Given this list of marker genes Pln (phospholamban), Hrc, Atp2a1, Mrln, Strit1, here is a description of the gene set: Mouse Gene Set: GOBP_REGULATION_OF_CALCIUM_ION_IMPORT_INTO_SARCOPLASMIC_RETICULUM studied in species Mus musculus Any process that modulates the frequency, rate or extent of calcium ion import into sarcoplasmic reticulum.